Given this list of marker genes MYO5A, ACTN4, FNBP1L, WASL, MYO1C, here is a description of the gene set: Movement of a vesicle along an actin filament, mediated by motor proteins. species: Homo sapiens Human Gene Set: GOBP_VESICLE_TRANSPORT_ALONG_ACTIN_FILAMENT